The following is a description of a gene set: EGR2 and SOX10-mediated initiation of Schwann cell myelination Human Gene Set: REACTOME_EGR2_AND_SOX10_MEDIATED_INITIATION_OF_SCHWANN_CELL_MYELINATION species: Homo sapiens, and this is the list of marker genes: ADGRG6, WWTR1, MPZ, LAMC1, YAP1, SOX10, POU3F1, PRX, NAB1, MAG, LAMA2, MBP, CYP51A1, UTRN, HDAC2, DAG1 (NCBI Gene Id 1605), SREBF2, POU3F2, GJB1, HMGCR, ADGRV1, DRP2, NAB2, LAMB1, EGR2, TEAD1, PMP22, SMARCA4, SCD5